Given this list of marker genes COQ4, THOC2, RARS2, ACBD6, SPG11, UBAP1, KIF5A, TBCD, CYP7B1, GPRC5B, ACTL6B (actin like 6B), PIGA, RNF170 (NCBI Gene Id 96586), SPART, CLCN4, SIGMAR1, B4GALNT1, ERLIN2, SELENOI, GBA2, SATB1, FUS (FUS RNA binding protein), ZFYVE26, WASHC5, ALS2, HEPACAM, GJC2, SPTLC1, CAPN1, DDHD2, TMEM63C, SPG7, here is a description of the gene set: Upper limb spasticity Human Gene Set: HP_UPPER_LIMB_SPASTICITY species: Homo sapiens